Given this list of marker genes ZDHHC21, TNFRSF1A, S1PR2, PPP1R12A, ROCK2, VCL, VEGFA (vascular endothelial growth factor A), IKBKB, CLDN5, TNF, PLCB1, CDH5, ROCK1, ADD1, F11R, IL1B, S1PR3, PROC, here is a description of the gene set: species: Homo sapiens Any process that modulates the frequency, rate or extent of endothelial cell development. Human Gene Set: GOBP_REGULATION_OF_ENDOTHELIAL_CELL_DEVELOPMENT